Given this list of marker genes CDADC1, APOBEC3D, AICDA, APOBEC3G (NCBI Gene Id 80065), APOBEC3C, APOBEC3H, APOBEC3A, APOBEC3B (apolipoprotein B mRNA editing enzyme catalytic subunit 3B), APOBEC3F, here is a description of the gene set: The removal of an amino group from a cytosine residue in DNA, forming a uracil residue. studied in species Homo sapiens Human Gene Set: GOBP_DNA_CYTOSINE_DEAMINATION